Given this list of marker genes Mmp7, Sppl2a, Mbtps1, Sppl2c, Sppl2b, Tgfb1, Aph1a, Ncstn, Aph1b, Rhbdd1, Psenen, Adam9, Mbtps2, here is a description of the gene set: studied in species Mus musculus The proteolytic cleavage of a transmembrane protein leading to the release of an intracellular domain. Mouse Gene Set: GOBP_MEMBRANE_PROTEIN_INTRACELLULAR_DOMAIN_PROTEOLYSIS